Given this list of marker genes LIF, VEGFA, BMP4, BMPR2, ERRFI1 (NCBI Gene Id 54206), IGF1, TCF21, FOXF1, ID1, BMP2, STRA6, here is a description of the gene set: Human Gene Set: GOBP_LUNG_VASCULATURE_DEVELOPMENT studied in species Homo sapiens The biological process whose specific outcome is the progression of a lung vasculature from an initial condition to its mature state. This process begins with the formation of the lung vasculature and ends with the mature structure. The lung vasculature is composed of the tubule structures that carry blood or lymph in the lungs.